The following is a description of a gene set: Reactome Pathway: Energy dependent regulation of mTOR by LKB1-AMPK Upon formation of a trimeric LKB1:STRAD:MO25 complex, LKB1 phosphorylates and activates AMPK. This phosphorylation is immediately removed in basal conditions by PP2C, but if the cellular AMP:ATP ratio rises, this activation is maintained, as AMP binding by AMPK inhibits the dephosphorylation. AMPK then activates the TSC complex by phosphorylating TSC2. Active TSC activates the intrinsic GTPase activity of Rheb, resulting in GDP-loaded Rheb and inhibition of mTOR pathway. part of: MTOR signalling species: Homo sapiens, and this is the list of marker genes: RRAGA, LAMTOR1, LAMTOR5, RRAGC, PRKAG2, PRKAB1, STRADA, MLST8, RRAGB, TSC1, CAB39, LAMTOR2, PPM1A, CAB39L, PRKAA2, TSC2, PRKAG3, RHEB, LAMTOR3, STK11 (NCBI Gene Id 6794), RPTOR, RRAGD, PRKAG1, PRKAA1, PRKAB2, STRADB, SLC38A9, LAMTOR4, MTOR